The following is a description of a gene set: species: Homo sapiens Human Gene Set: GOBP_ASSOCIATIVE_LEARNING Learning by associating a stimulus (the cause) with a particular outcome (the effect)., and this is the list of marker genes: CTNS, TAFA2, TACR1, PPT1, ABL1 (ABL proto-oncogene 1, non-receptor tyrosine kinase), SNAP25, CRH, CREB1, TANC1, TNR, APP, MECP2, SRF, SLC7A11, NPTX2, ADAM2, PGRMC1, NEUROD2, DBH, KMT2A, ABCC8, UCN, MAP1A, ABCA7, CLSTN2, LRRN4, MEIS2, CHRNB2, FOS, PIAS1, SHANK1, RELN, B4GALT2, DRD1, DEAF1, IFT20, B3GAT1, PLN, ATXN1, CLN8, KRAS, ASIC1, ADCY3, PDE1B, BRAF (NCBI Gene Id 673), BTG2, GRIN2A, PDE8B, SPECC1, DRD3, SLC1A1, FOXB1 (NCBI Gene Id 27023), GRIA1, COMT, TPBG, TTC36, DRD2, NDRG4 (NCBI Gene Id 65009), PIANP, GABRA5, HRH1, SLC6A4, KIT, OPRK1, TAC1, GRIN1, EIF4A3, NF1, RIC8A, DRD5, SYNGAP1, CDK5 (NCBI Gene Id 1020), BRSK1, CSMD1, HMGCR, TUBA1A, NOG, DDHD2, RGS14, LGMN, TSC1, HIF1A, CLN3, SLC6A1, RAPGEF3, PPP1R1B, NETO1, NPS, RAG1, TBR1, NRGN, ITGB1, ATP1A2